Given this list of marker genes Coq4, Pdss2, Coq6, Coq7, Pdss1, Coq3, Coq5, Coq9, here is a description of the gene set: Mouse Gene Set: GOCC_UBIQUINONE_BIOSYNTHESIS_COMPLEX studied in species Mus musculus A protein complex composed of enzymes and accessory factors of the ubiquinone (CoQ) biosynthesis pathway. In E. coli, the complex is composed of seven proteins: UbiE, F, G, H, I, J and K. In eukaryotes, the complex is located on the matrix face of the inner mitochondrial membrane and includes COQ3, COQ4, COQ5, COQ6, COQ7, COQ9.